The following is a description of a gene set: studied in species Mus musculus Mouse Gene Set: GOBP_ADENYLATE_CYCLASE_INHIBITING_G_PROTEIN_COUPLED_ACETYLCHOLINE_RECEPTOR_SIGNALING_PATHWAY An adenylate cyclase-inhibiting G protein-coupled receptor signaling pathway initiated by acetylcholine binding to its receptor, and ending with the regulation of a downstream cellular process., and this is the list of marker genes: Chrm5, Chrm1, Hrh4, Oprm1, Chrm3 (cholinergic receptor, muscarinic 3, cardiac), Hrh3, Chrm4, Chrm2